The following is a description of a gene set: Mouse Gene Set: GOBP_RESPONSE_TO_ZINC_ION Any process that results in a change in state or activity of a cell or an organism (in terms of movement, secretion, enzyme production, gene expression, etc.) as a result of a zinc ion stimulus. studied in species Mus musculus, and this is the list of marker genes: Alad, Mtf1, Ass1, Aldob, Slc30a3, Lta4h, Gpr39, Glra1, Mt4, Slc30a8, Glra3, Tspo, Gabrb3 (GABRB3, gamma-aminobutyric acid type A receptor subunit beta 3), D2hgdh, Glra2, Pln (phospholamban), Slc30a2, Ggh, Zfp658, Kcnk3, Mt1, P2rx4, Ddx19a, Gsk3b, Hvcn1, P2rx5, Slc30a1 (NCBI Gene Id 98435), P2rx7, Pam, Sod2, Zfp735, Slc30a4, Slc30a5, Aanat (NCBI Gene Id 11298), Gabrg2, Zfp616, Mt3, Abcc8, Cps1, Crip1, Grin2a, Khk, Creb1, Slc30a10, Mt2, Haao, Otc, Th